Given this list of marker genes Ift81, Prss40, Mrpl9, Trap1, Rnaseh2a, Gm6096, Pdlim1, Nsa2, Xpnpep1, Slc2a3, Aldoa, Oplah, Dhcr7, Mir376c, Tm4sf5, Bcas1, Taf1c, Agap3, Csf1r, Adipor2, Tenm4, Rab43, Rhbdl2, Txndc9 (NCBI Gene Id 98258), Jakmip1, Bcl2l1, Gm15411, Azin2, Lztr1, A430005L14Rik, Pou6f1, Ahsa2, Rnf181, Banp, Sema4d, Patz1, Inpp5f, Aida, Gm8192, Eif4e2, Mir7035, Tulp3, Ccdc116, Atcay, Cib1, Runx3, Ankrd10, Sirt7, Galnt17, Ppp1r9a, Slc1a1, Npr3, Syt8, C130036L24Rik, Hhip, Usf2, Gm23090, Lratd1, Mpi, Gm12936, 1700029H14Rik, Slc38a8, Wdfy3, Zbtb8a, Dbn1, Ogt, Irf8, Gm3329, Tmem202, Cep95, Gm22935, Gm12608, Uba52, Wnt5b, 4933427D14Rik, Cklf, Ccndbp1, Rbm20, Snord17, Zfp809, Or7c74, Tifab, Or10ad1, Mbtps2, Oser1, 1700019D03Rik, Top3b, Zfp975, Ushbp1, Fcgr3, Asl, Mgst2, Tubgcp3, Gm5532, Krtap20-22, Lrriq4, Capza1, Gm19705, Fbxl22, Tmem265 (transmembrane protein 265), Gm10475, Hspa4, Mb (NCBI Gene Id 223670), Chrna9 (NCBI Gene Id 69992), Ercc8, Mical2, Lrrc23, Hdgf, Rad51ap2, Uhrf1, Mir103-2, Mcf2l, Tulp1, Ssbp4, Plekha6, Tlr2, Cygb, Oaz3, Pkdcc, Pdk1, Gigyf2, Snrnp25, Olig3, Znfx1, Slc39a2, Mphosph9, Triobp, Eif3k, Clec2d, Setd1a, Fanca, Aste1, Snx1, Lyg1, Stk36, Ccdc47, Abcc3, Fam186b, Zfp1006, Enah, Rnf125, Arhgap28, Taldo1, Mrpl22, Uba2, Nbeal2, Myo18a, Zfp747l1, Tbx15, Ubr7, Rcbtb1, Acsbg3, Safb2, Lrrc42, Gnb1, Dnajc17, Nfat5, Sun1, Synpo2, Fat2, Arf4, Rfwd3, Syt3 (synaptotagmin III), 4933408N05Rik, Pygb, Ptges3, Tpk1, Ctbp2, Calcoco2, LTO1, Sec24c, Mir7238, Nipbl, Rab27a (RAB27A, member RAS oncogene family), AU016765, Rsf1, Hsp90ab1, Slc22a2, Gm13094, H2-M5, Itih3, Gm23382, Tyw1, 9430007M09Rik (NCBI Gene Id 77270), Zfpm1, 5730409E04Rik, Apob, Lhfpl7, Dsc1, Rps12-ps7, Pold2, Txndc17, Myo15a, Ech1, Shmt1, Chl1, Arhgap12, Pou2f2, Nadsyn1, Pi4ka, Gm12339, 1700023H06Rik, Il4, Sgip1, 4930447F24Rik, Dars2, Tm2d2, Pzp, Atp5f1a, Or6n1, Cyp4a28-ps, Mrm2, Gpr85, Ckap2, Trim67, St6gal1, Hsd3b7, Ppfibp2, Rad54l, Gm43772, Tnfrsf1a, Fkbp8, Ube2k, Gm17806, Klf1, Cp, Lonrf2, Lypd6b, Baz1b, Eva1c, Luc7l2, 1700036A12Rik, Ptpn11, Nudt1, Crb2, Gm22972, Cdr2l, Arhgap26, Poc1a, Gm24400, Acyp1, Fcna, Ppp4r4, Zfat, Atrnl1, Gm11198, Cars2, Ninj2, Rfx3, Rbp7, Gm23123, Rnf4, Foxc1, Gm28874, Epdr1, Gamt, Psd, Hcls1, Med18, Utp25, Psma3, Gprc5c, Gm4349 (predicted gene 4349), Gm24592, Mtfr1, Hexim2, Platr22, Ggt7 (gamma-glutamyltransferase 7), Cldn22, 1110038B12Rik, Gm12313, Hkdc1, Atp8b3, 1110028F18Rik, Cltc, Atp6v0a1, Park7, Pax6, Sema4g, Dnah2, Ipo13, Dlgap5, Ccdc9, Srsf1, Lingo4, Kcnk6 (NCBI Gene Id 52150), Gm12740, Nedd4, Rassf9, Rhot1, Gm15895, Zmiz2, Tprg1l, Tbc1d9b, Pcdh19, Dnaaf9, Vamp1, Gnl3, Smpd1, Cfap74 (NCBI Gene Id 69880), Prickle4, Tmco3, Hoxa11, Tagln2, Carhsp1, Adgrl3, Vpreb1a, Nol11 (nucleolar protein 11), Mrpl21, Gm25482, Hoxa7, Sox15, Lgals4, Fbxl15, Ebf2, Psmd7, Bcar3, Cln3, Zfp609, Gm25489, Tmem242, Maf, Timm13, Cerk, Iho1, Vwf, Phactr4, Sp1, Srrm1, Otud4, Gm3830, Itgb5, Ppp2r5c (protein phosphatase 2, regulatory subunit B', gamma), Zfp101, Atp5mj, Atg16l1, Foxm1, Gm22881, Hoxa11os, Adgra2, Pisd-ps1, Ccdc50, Ift172, Tmem63c, C030013C21Rik, Efna3, Tcp11, Ddr1, Vps72, Sulf1, Uvrag, Ptbp1, Clcn7, Prkab1, Pcp4l1, Babam2, Grin3b, Zfp36l1, Ube4a, Gm12924, Shroom3, Gm14133, Zfp318, Ralbp1, Btbd18, Pcmtd2, Rabl6, Gripap1, Aatf, Gm26579, Agpat2, Zfp106, Sf3b5 (splicing factor 3b, subunit 5), Ltbp3, Pick1, Rab3gap1, Hmgb1, Ndfip2, Zbtb25, Unc13b, Terf2, Zbtb34, Cdkn1a, Mrpl14, Relb, Mtmr3, Aars1, Fbxo10, Ntpcr, Tjp2, Zp1, Gm8398, Dlk1, Fh1, Trpm1, Brpf1, Zfp27, Iscu, Gm5258, Atxn2, Atp8b4, Spg21, 3110067C02Rik, Ywhag, Trp53cor1, Gm5084, Ciao3, Paxip1, Fgfr2, Dnajc11, Mxd3, Itpr2, Slc2a9, Zmynd12, Clns1a, Aifm1, Ybx3 (NCBI Gene Id 56449), 6430548M08Rik, Cnppd1, Gpr62, 1700001O22Rik (RIKEN cDNA 1700001O22 gene), Lmo2, Ube2i, Rnf25, Ubxn1, Gm16096, Thap6, Strn4, Eri3, Gm9887, Oas2, Gm26885, Fndc11, Fastkd5, Slc8a2, 1110002J07Rik, Uts2r, Lgmn, Mepce, Ifrd1, Smtn, Srpk1, Gm8213, Mgat5, Akr7a5, Atg2a, Arrdc3, Tns3, Cse1l, Eif5a, Zbtb1, Gm26070, Dhtkd1, Gm29243, Elp5, Ccr4, Zfp354b, Tram1, Gm2800, Elac2, Rbm47, Psmd4, Ncapg2, Tmem61, 2810407A14Rik (NCBI Gene Id 70211), Slco1c1, Tekt5, Gm12980, Trp53i13, Prrt3, Ttc33, Znrf4, Ralgps2, Lbhd1, Rsf1os2, Ankrd40, Slc7a7, Tubg2, Lat2, Surf6, Rora, Lifr, Sass6 (NCBI Gene Id 72776), Sinhcaf, Phox2b, Usp21, 9430015G10Rik, Ly75, Cbfb, Tpd52 (NCBI Gene Id 99538), Pomgnt1, Map4k4, Mzf1, Sptan1, Map2k1, Selenof, Ift122, Sart3, Lpin2, Babam1, Samd10, Ddb2, H3c11, Tmem179, Rell1, Amigo1, Polrmt, Tcea2, Atp6v0d1, Thbs3, Gm30292, Metap2, Gm25862, Ercc6l, Sox2ot, Paqr8, Mfap1b, Mir7668, 2610507I01Rik, Spry4, Actr8, Reps1, Kat2b, Gpr157 (NCBI Gene Id 269604), Ncoa4, Runx2, As3mt, Cyp11a1, Golga5, Gm13594, Thbd, Elp6, Gjb3, Tra2a, Anapc15, Adamts19, Wfs1, Lbr, 4931406C07Rik, Gm4577, Gfi1, Scn9a, Xab2, Chn1, Mrpl50 (mitochondrial ribosomal protein L50), Smg7, Plcxd2, Zmat1, Appbp2os, Cpeb2, Cdh13, Ints13, Mdk, Tmeff2, Gm26684, Tbc1d10b, Syngap1, Ubap2, Tpd52l2, Gm25184, Rwdd4a, Farsb, Hvcn1, Slc35f5, Crispld2, Vars2, Nvl, Tmem53, Pask, Kdm5a, A430072P03Rik, Eif2ak4, Tbl3, Mlxip, Unc13a (NCBI Gene Id 73695), Ppard, Aifm3, Gm14175, Fhip2b (NCBI Gene Id 638224), Gm8969, Adar, Atp6v1e1, Acat1, Taf1d, 1700030C12Rik, here is a description of the gene set: from publication Yevshin I, Sharipov R, Kolmykov S, Kondrakhin Y, Kolpakov F (PMID 30445619) Mouse Gene Set: ZFP874A_TARGET_GENES studied in species Mus musculus